Given this list of marker genes METTL9, CD93, GAB2, LYZ, NOTCH2, S100A12, CYRIA, STX12, PLXNC1, LILRB1, AKR1A1, FLVCR2, PILRA, ANXA2, MNDA, CSF2RB, SLC15A3, GPX1, MGAT1, S100A8, CD14, AP1S2, TLR2, MANBA, DUSP3, IFNGR2, RIN2, CD36, HK3, CLEC7A, GNG10, GNS, PTTG1IP, SCPEP1, FCER1G, SDCBP, GLB1, ACSL4, ALOX5, COQ2, TALDO1, UBA3, PDLIM5, NSF, FCGR2A, KLF10, CEBPD, ZMIZ1, FGL2, FCN1, SIGLEC9, MFSD1, IRF8, SLC11A1, FGR, TYMP, HSBP1, MICAL2, ILK, MED8, NFE2, FBP1, TUT7, ATP10D, ANXA2P2, ATP6V0B, MEGF9, SH2B3 (SH2B adaptor protein 3), TNFAIP2, DOK1, SYK, CSF3R, C5AR1, NPC2, PSAP, ADAP2, TNFSF13, EIF4E2, KCTD12, E2F3, CTSA, ARHGAP26, PPFIA1, FTL, IRAK3, GABARAP, KLF4, SPI1 (NCBI Gene Id 6688), SNX10, CLEC4A, BCL6 (NCBI Gene Id 604), FKBP15, FPR1, ASAH1, SLC7A7 (solute carrier family 7 member 7), RXRA, MTMR14, NUP62, CSTA, CORO1C, HCK, VNN2, CHST15, CKAP4, S100A9, SIRPA, OAZ1, PLBD1, UBE2D1, BID, PLXNB2 (NCBI Gene Id 23654), NCF2, DIAPH2, APOBEC3A (apolipoprotein B mRNA editing enzyme catalytic subunit 3A), WASHC4, CYBB, VAMP3, CCR1, EXOC1, VCAN, DUSP6 (dual specificity phosphatase 6), HSPA1A, PTGS1 (prostaglandin-endoperoxide synthase 1), IL6R, GCA, TNS3, CDC42EP3, LY96, SLC16A6, SEMA4A, IFI30, FEZ2, PCTP, HEXB, FUT4, DAPK1, CREG1, QPCT, GRN, TPP1, ABHD5, IFNGR1, SLC27A3, LILRA2, NEU1, PTPRE, LAT2, CTSS, S100A11, GLRX2, MARCKS, GLRX, IGSF6, LILRB3, CTNNA1 (catenin alpha 1), NADK, TIMP2, GAPDH, RNF130, ATP6V0D1, PRKCD, FOS, NAGK, LGALS3, NIT1 (NCBI Gene Id 4817), CASP1, CTSB, YBX3, STX7, ADGRE2, TIMM8B, RAB32, CLCN6, LILRB2, TBC1D2 (NCBI Gene Id 55357), NCOA4, CAPZA1, TBC1D12 (TBC1 domain family member 12), PISD, NPTN, RAB31, GLUL, CTSH, ARHGEF10L, PGD, SMCO4, ITGAM, KCNMB1, PLCG2, ATP6V1A, NOD2, NCF1C, SLC31A2, CAPG, PLSCR1, TNFRSF10B, SNX11, CTBP2, DPYD, DMXL2, here is a description of the gene set: Genes down-regulated in comparison of naive CD4 T cells versus day 0 monocytes. Human Gene Set: GSE22886_NAIVE_CD4_TCELL_VS_MONOCYTE_DN Immune cell-specific expression is one indication of the importance of a gene's role in the immune response. In order to identify such patterns, we set out to broadly profile gene expression in a variety of immune cells. from publication Abbas AR, Baldwin D, Ma Y, Ouyang W, Gurney A, Martin F, Fong S, van Lookeren Campagne M, Godowski P, Williams PM, Chan AC, Clark HF (PMID 15789058) studied in species Homo sapiens